The following is a description of a gene set: Human Gene Set: GOBP_REGULATION_OF_CELL_DIFFERENTIATION_INVOLVED_IN_EMBRYONIC_PLACENTA_DEVELOPMENT studied in species Homo sapiens Any process that modulates the rate, frequency or extent of cell differentiation that contributes to the progression of the placenta over time, from its initial condition to its mature state., and this is the list of marker genes: GCM1, ELF5, STK4, SNAI1, STK3